Given this list of marker genes CTNNB1, FERMT1, SPINK5, WNT10B, WNT5A, here is a description of the gene set: studied in species Homo sapiens The growth phase of the hair cycle. Lasts, for example, about 3 to 6 years for human scalp hair. Human Gene Set: GOBP_ANAGEN